The following is a description of a gene set: EEG with spike-wave complexes (2.5-3.5 Hz) Human Gene Set: HP_EEG_WITH_SPIKE_WAVE_COMPLEXES_2_5_3_5_HZ The presence of complexes of spikes and waves (2.5-3.5 Hz) in electroencephalography (EEG). species: Homo sapiens, and this is the list of marker genes: KCNA2, SLC2A1, GABRG2, GABRB3, SETD1B, JRK, CACNA1H, GABRA1